The following is a description of a gene set: species: Mus musculus The creation of a single organelle from two or more organelles. Mouse Gene Set: GOBP_ORGANELLE_FUSION, and this is the list of marker genes: Vps16 (VSP16 CORVET/HOPS core subunit), Chmp1a, Syt2, Plekhm2, Bet1, Yme1l1, Usp30, Tgfbrap1, Nkd2, Mul1, Yipf5, Vps18, Rab20, Ankrd27, Uso1, Syt8, Chchd3, Vti1a, Stx7, Vamp4, Bcl2a1a, Doc2g, Slamf1, Rims2, Chmp2a, Bak1, Vps41, Pld6, Cidec, Mfn1, Rab14, Cideb, Znrf2, Cltrn, Pcdhga3, Gdap1, Cplx3 (NCBI Gene Id 260379), Tom1 (NCBI Gene Id 21968), Spg11, Vps39, Eea1, Fis1, Pla2g4a, Erc2, Ldah, C2cd5, Pnpla2, Stoml2, Syt3, Rab34, Vamp3, Syt4, Stx3, Cplx1, Prkn, Vps8, Stx19, Chmp5, Sec22b, Stx6, Syt5, Gosr2, Vav3, Clstn3, Mff, Rab7b, Diaph3, Parl, Chmp1b, Cplx2, Hid1, Yipf4, Dysf, Atp13a2, Plekhm1, Rims1, Gnai3, Zdhhc6, Tmem175, Anxa2, Yipf7, Cln3, Septin8, Stx12, Samd9l, Prrt2, Coro1a, Sphk1, Vps11, Vcpip1, Opa1, Pikfyve, Ankfy1, Stx2, Rubcnl, Stxbp1, Tbc1d4, Cacna1b, Bnip3, Huwe1, Rcc1l, Stx8, Adck1, Chmp4b, Rimbp2, AU040320, Vamp1, Stx5a, Chmp6, Vat1, Rph3al, Anxa1, Mfn2, Chp1, Vti1b, Mcl1, Trabd, Dnm1l, Miga1, Grik5, Afg3l1, Stx1a, Rab8a, Snca, Vamp9, Bcl2a1b (NCBI Gene Id 12045), Vamp2, Miga2, Cidea, Thg1l, Cyp26c1, Uvrag, Stx1b, Arl8b, Rufy1, Rph3a, Stx16, Rab7, Snap25, Vps4a, Cav2, Bloc1s6, Chmp4c, Mtch2, Snapin, Pip4k2a, Pip4k2b, Znrf1, Tfrc, Vamp8, Mief1, Nme3, Pla2g5, Trim9, Sox30, Afg3l2, Snap47, Bnip1, Stx4a, Stxbp6, Rufy4, Syt9, Chmp7, Syt13, Rab4b, Snap29, Doc2a, Gosr1, Snph, Syt11, Kif5b, Erc1, Oma1, Chmp2b, Bax, Cplane2, Snap23, Rab39, Stx17, Chmp1b2, Trarg1, Stx11, Chmp3, Bcl2a1c, Cplx4, Bcl2a1d, Syt1, Doc2b, Rab3a (RAB3A, member RAS oncogene family), Syt7, Fundc1